Given this list of marker genes SFN, IFNA7, IFNA2, STAB1, IFNA5, COL8A1, C5AR1, CARD9, CFI, IFNA16, IFNA8, CFD, FCER1G, ARRB2, ST14, TLR4, CFB (complement factor B), IFNA10, IFNA21, CR1, IL1A, ADAMTS20, C3AR1, ITGB4, TBC1D8, CCRL2, TYROBP, here is a description of the gene set: Many vaccines induce protective immunity via antibodies. Systems biology approaches have been used to determine signatures that can be used to predict vaccine-induced immunity in humans, but whether there is a 'universal signature' that can be used to predict antibody responses to any vaccine is unknown. Here we did systems analyses of immune responses to the polysaccharide and conjugate vaccines against meningococcus in healthy adults, in the broader context of published studies of vaccines against yellow fever virus and influenza virus. To achieve this, we did a large-scale network integration of publicly available human blood transcriptomes and systems-scale databases in specific biological contexts and deduced a set of transcription modules in blood. Those modules revealed distinct transcriptional signatures of antibody responses to different classes of vaccines, which provided key insights into primary viral, protein recall and anti-polysaccharide responses. Our results elucidate the early transcriptional programs that orchestrate vaccine immunity in humans and demonstrate the power of integrative network modeling. Genes up-regulated in peripheral blood mononuclear cell 3d vs 0d in adults (18-45) (anti-DT antibody-correlation profile) after exposure to Menactra, time point 3D from publication Li S, Rouphael N, Duraisingham S, Romero-Steiner S, Presnell S, Davis C, Schmidt DS, Johnson SE, Milton A, Rajam G, Kasturi S, Carlone GM, Quinn C, Chaussabel D, Palucka AK, Mulligan MJ, Ahmed R, Stephens DS, Nakaya HI, Pulendran B (PMID 24336226) Human Gene Set: LI_PBMC_MENACTRA_AGE_18_45YO_ANTI_DT_ANTIBODY_CORRELATION_PROFILE_3DY_UP studied in species Homo sapiens